The following is a description of a gene set: Human Gene Set: TAKEDA_TARGETS_OF_NUP98_HOXA9_FUSION_3D_DN species: Homo sapiens Genes down-regulated in CD34+ hematopoetic cells by expression of NUP98-HOXA9 fusion off a retroviral vector at 3 days after transduction. NUP98-HOXA9, the chimeric protein resulting from the t(7;11)(p15;p15) chromosomal translocation, is a prototype of several NUP98 fusions that occur in myelodysplastic syndromes and acute myeloid leukemia. We examined its effect on differentiation, proliferation, and gene expression in primary human CD34+ hematopoietic cells. Colony-forming cell (CFC) assays in semisolid medium combined with morphologic examination and flow cytometric immunophenotyping revealed that NUP98-HOXA9 increased the numbers of erythroid precursors and impaired both myeloid and erythroid differentiation. In continuous liquid culture, cells transduced with NUP98-HOXA9 exhibited a biphasic growth curve with initial growth inhibition followed by enhanced long-term proliferation, suggesting an increase in the numbers of primitive self-renewing cells. This was confirmed by a dramatic increase in the numbers of long-term culture-initiating cells, the most primitive hematopoietic cells detectable in vitro. To understand the molecular mechanisms underlying the effects of NUP98-HOXA9 on hematopoietic cell proliferation and differentiation, oligonucleotide microarray analysis was done at several time points over 16 days, starting at 6 hours posttransduction. The early growth suppression was preceded by up-regulation of IFNbeta1 and accompanied by marked up-regulation of IFN-induced genes, peaking at 3 days posttransduction. In contrast, oncogenes such as homeobox transcription factors, FLT3, KIT, and WT1 peaked at 8 days or beyond, coinciding with increased proliferation. In addition, several putative tumor suppressors and genes associated with hematopoietic differentiation were repressed at later time points. These findings provide a comprehensive picture of the changes in proliferation, differentiation, and global gene expression that underlie the leukemic transformation of human hematopoietic cells by NUP98-HOXA9. from publication Takeda A, Goolsby C, Yaseen NR (PMID 16818636), and this is the list of marker genes: CYP7B1, CCL7, IL7R, ALOX5, NDFIP2, MAFB, CXCL5, OSM, HBE1, LIF, S100A8, PRG3, TGFBI, ATP10D, ENTPD1, HGF, APOL4, FCGR2A, ADGRG3, PPBP, CD163, PLPP1, ALB, LINC02806, CLEC10A, S100A9, TEX15, ETS1, FCGR2B, RAPGEF5, GLUL